Given this list of marker genes LRRC8C, LRRC8A, LRRC8D, SLC6A11, SLC16A6, SLC36A1, SLC6A6, SLC6A13, here is a description of the gene set: studied in species Homo sapiens The directed movement of an alkanesulfonate into, out of or within a cell, or between cells, by means of some agent such as a transporter or pore. Alkanesulfonates are organic esters or salts of sulfonic acid containing an aliphatic hydrocarbon radical. Human Gene Set: GOBP_ALKANESULFONATE_TRANSMEMBRANE_TRANSPORT